The following is a description of a gene set: from publication Chen Y, Wang X (PMID 31504780) species: Mus musculus Mouse Gene Set: MIR_3070_5P Genes predicted to be targets of miRBase v22 microRNA mmu_miR_3070_5p in miRDB v6.0 with MirTarget v4 prediction scores > 80 (high confidence targets)., and this is the list of marker genes: Parvg, Gpc1, Kcnq1, Rhobtb1, Btg2, Bicd2, Gabrb2, Lrp1, Kcnq2, Abca1, Trem6l, Taok3, C1qtnf3, Ankrd13b, Slc35d3, Chst4, Elovl2, Tbx4, Zfp385b, Ankrd52 (ankyrin repeat domain 52), Tpcn1, Sfmbt1, Ikzf4, Kmt2c, Ptpa, Asb13, Riiad1, Arhgef17, Oaz2, Mapk8ip3, Sbk1, Zpr1, Sorcs2, Ep300, Epha8, Smg5, Pcbp4, Akt3 (NCBI Gene Id 98462), Pigq, Cops7b